Given this list of marker genes Gp1ba, F12, Klkb1 (kallikrein B, plasma 1), F9, Gp1bb, Kng2, Gp9, here is a description of the gene set: electronically inferred by orthology from the curated human pathway This event has been computationally inferred from an event that has been demonstrated in another species.<p>The inference is based on the homology mapping from PANTHER. Briefly, reactions for which all involved PhysicalEntities (in input, output and catalyst) have a mapped orthologue/paralogue (for complexes at least 75% of components must have a mapping) are inferred to the other species. part of: Regulation of clotting cascade species: Mus musculus Reactome Pathway: FXIIa, PKa-dependent activation of coagulation pathway